Given this list of marker genes MT-TS2, MT-CO1, MT-TQ, MT-ND6, SCO2, MT-TF, MORC2, MT-CO2, ATP7B, NEFL, MT-ND1, MT-TW, MT-TH, MT-CO3, MT-TL1, MT-ND4, MT-ND5, here is a description of the gene set: studied in species Homo sapiens Human Gene Set: HP_MIXED_DEMYELINATING_AND_AXONAL_POLYNEUROPATHY Mixed demyelinating and axonal polyneuropathy